Given this list of marker genes PXN (NCBI Gene Id 80229), IP6K1, ZNF395, LMF2, UNC93B1, POLD3, LCAT, IFFO1, PRKAR2A, MX1, CHMP1A, RNASE1, ENDOD1, BLVRB, MSRB2, ITGB5 (integrin subunit beta 5), IL10RA, RNF220, TPCN1, PMM1, ALDH6A1, RIPOR1 (RHO family interacting cell polarization regulator 1), ARHGAP1, S1PR4, REPS2, STBD1, AKIP1, DOK2, TESC, SNX6, ABCC10, TREML2, ASRGL1, FES, MICAL1, SGSH, FKRP, TNS4 (NCBI Gene Id 84951), SLC7A8, SEC14L1, GNAI2, ZBED1, MTCH1, AP1B1, WDR45B, ADCY2, ELF4, CALHM2, HYI, MPG, IFIT3, HDAC5, LPAR6, ACSBG1, DAP, RGL2, KLF7, C2CD2L, CENPM, DGKD, GNPAT, CCR6, FGF16, SAT1, XPO6, CRYL1, PTPN18, SYNE3, STAB1, PAQR4, GPSM3, TPP1, SORD, RNF114, CD302, HERC5, DPEP2, GORASP1, FUCA1, EPHB2, VILL, PCDH1, CNNM4, CDKN1C, MIA3, ZC3H3, DCLK1, CAPN1, NSD2, HK1, IMPA2, MEF2C, FAM111A, GOLGA2P5, STX10, GGNBP2, HABP4, TENT5A, EIF4EBP2, SCIN, ENTPD6, NENF, CORO1B, LHPP, ARFGAP1, LMO2, FGD2, ZNF185 (zinc finger protein 185 with LIM domain), TSPYL2, PTPRH, SIK1, RNASE6, CHN2, CD180, CTNNBIP1, PARL, CST3, ASIC3, TMEM134, CACNA1I, TNFRSF11A, WASF2, DALRD3, IGFBP4, RAD9A, ZNF862, RERE, POLR2A, ITSN1, TRMT1 (tRNA methyltransferase 1), TOP3A, NUP214, RGS14, PPP1CB, ABCC5, RFNG, POLB (NCBI Gene Id 5423), XPNPEP3, OXA1L, LYL1, NCF4, PRDM4, VPS39, TNFSF10, CD101, PHKA2, PIP4K2B, ZNF671, PARP4, TMCO6, PDGFC, ABHD11, VAMP2, PANK2, SHLD2, ARSA, NUMA1, PDXDC1, VPS13D, ZNF516, AP2A2, PLCB2, PEX11B, WAS, GABBR1 (gamma-aminobutyric acid type B receptor subunit 1), PLSCR4, INPP5D, RABGGTA, CHN1, TSC22D3, NPHP4, GAS7, IL23A, MX2, CORO2A, CASP10, FOXJ2, EGLN2, MKRN1, TRIM3, INTS1, OSBPL3, SLC35C1, SIRT7, ARHGAP4, TMT1A, CNPY3, DUSP3, MAN2A2, ABHD10, TBC1D9B (NCBI Gene Id 23061), HERPUD1, NFRKB, CTDSP2, SLC25A1, PDP1, OAS1, WBP1L, IFIT1, TRADD, here is a description of the gene set: from publication Cipolletta D, Feuerer M, Li A, Kamei N, Lee J, Shoelson SE, Benoist C, Mathis D (PMID 22722857) Genes down-regulated in CD4 T cells over-expressing FOXP3 and Pparg1 isoform of PPARG: untreated versus pioglitazone. species: Homo sapiens Human Gene Set: GSE37533_UNTREATED_VS_PIOGLIZATONE_TREATED_CD4_TCELL_PPARG1_AND_FOXP3_TRASDUCED_DN We identified Pparg as a major orchestrator of the phenotype of adipose-tissue resident regulatory T cells (VAT Tregs). To explore the contribution of Pparg1 and 2 in the generation of the VAT Tregs-specific gene signatures, CD4+FoxP3- T cells were transduced with Foxp3+/- Pparg1 (or Pparg2), treated with Pioglitazone or vehicle, and double sorted for microarray analysis.